The following is a description of a gene set: from publication Derbinski J, Gäbler J, Brors B, Tierling S, Jonnakuty S, Hergenhahn M, Peltonen L, Walter J, Kyewski B (PMID 15983066) Human Gene Set: GSE2585_THYMIC_DC_VS_MTEC_DN Genes down-regulated in thymic dendritic cells versus medullary thymic epithelial cells (mTEC). Gene expression in different thymic stromal cells and subsets thereof was analyzed in 6-12 week old wild type (C57BL/6) and Aire knock-out (mixed background) mice. Thymic stromal cells were purified by sequential enzymatic digestion (collagenase, collagenase/dispase and trypsin) followed by gradient centrifugation and FACS sorting. Sort criteria were as follows: dendritic cells (CD11c+, F4/80 -), macrophages (F4/80+, CD11c-), cTECs (CD45–/lo, CDR1/Ly51+, Ep-CAM+) and mTECs (CD45–/lo, CDR1/Ly51–, Ep-CAM+). mTECs of wild-type and Aire knock-out mice were further subdivided according to CD80 expression levels. For microarray analysis total RNA from thymic stromal cell samples of two independent experiments was pre-amplified and biotinylated by two rounds of cDNA synthesis and in vitro transcription. Fluorescence readings were evaluated by using Microarray Suite 5.0 software. studied in species Homo sapiens, and this is the list of marker genes: ZNF195, RPL11, GP6, GFM1, DSTYK, BMS1P20, DIAPH3, SF3A2, CSH2, FAM171A1, ACSBG2, MED18, CD48, SMARCA5, CD247, IFI44L, H3C3, CXCL13, PRKAA1, TBC1D8, RSAD2, IRAK3, SENP7, OLFML2A, IFIT3, MAP3K7, PIP4K2C, PPFIBP2, CCL13, VPS33B, LARP4B, NECTIN3, OSGEPL1, RASL11B, THBS1, SMARCA1, TRGV5, UTP6, RANBP17, TNFSF10 (NCBI Gene Id 8743), DDX6, AGTPBP1, ELL, UTP11, YAP1, IFI6, GTF2H3, SPART, MEP1A, IFI27, MRTFA, ATP6V1B2, RHOH, MNDA, BARX2, ZNF335, UBE2NL, NBEA, IFNGR1, BLTP1, TNN, BTF3, PSMD4 (NCBI Gene Id 5710), NOL6, RYK, AQP9 (aquaporin 9), HNRNPA1, CHRM5 (cholinergic receptor muscarinic 5), APPL2, HECTD3, AUP1, RNPS1, BCL9, PITRM1, GYPA, DPYS, FBN1, PPP1R3A, KIF3B, CYP7A1, STIMATE, SRF, POLR2A, MFN2, MOG, MRPL44, MED24, PIP5K1B, SNAPC3, ZNF157, CDC37L1, SIRT5, SYCP2, ELSPBP1, EPS8L3, RNMT, SFI1, DNASE1L1, ISG20, AOX1, PRKAB1, GK2, KRT14, PDGFD, UBQLN3, IL36RN, SOCS6, RNF19B, IFITM1, NACA, SLC7A2, CCR5, CAPN10, NCAPG2, KCNJ3, PODXL, TNFRSF21, TCF4, LARP1, RPS6KB1 (ribosomal protein S6 kinase B1), CLCN2, IGF2R, ASPA, HNRNPU, TSPAN12, EFCAB2, DCAF1, ISG15, OTUD3, PSG3, CCDC170, DDR1, ALB, ZNF778, FZD3, PRR13, CLEC2D, KDM4D, MAFB, CLIC4 (chloride intracellular channel 4), TTPA, MLLT11, STOML1, SZT2, ZNF253, OAS2, LRRC61, CLEC4E, LAP3, EXO5, EIF4G3, S100A11, THBS2, NCSTN, STK4, SIN3B, DOK5 (docking protein 5), KIR2DL1, PLSCR1, IFITM3, PRR14L, PLAC8, CCR7, TRPM1, PTGDR, CDK18 (NCBI Gene Id 5129), POLR1F, SLC8A1, IQSEC1, STX17, ACTR8, TMBIM6, GSTK1, CNGB1, DEDD, DDIT3, OTULINL, GPR183, UBIAD1, ST7L, STRN3, UROD, HGS, CYP2C8, RNF24, THTPA, RETREG3, WHRN, RNF17, SNX16, CXCL10, SEMA3D, REL, CPSF7, NDUFA9, SKIC2, PSMA6, RPL22, BNC2, WBP11